Given this list of marker genes MYL2, LDB3, MYBPC3, PSEN1, ACTC1, POLG2, TRPM4, FLNC, PRKAG2, LMNA, TNNC1, PSEN2 (presenilin 2), CDH2, TNNI3K, MYOZ2, DSG2, SCN5A, CTNNA3, here is a description of the gene set: A conduction block of the left branch of the bundle of His. This manifests as a generalized disturbance of QRS morphology on EKG. Human Gene Set: HP_LEFT_BUNDLE_BRANCH_BLOCK species: Homo sapiens Left bundle branch block